Given this list of marker genes Fcf1, Abt1, Tbl3, Nop9, Rcl1, Utp23, here is a description of the gene set: Endonucleolytic cleavage within the 5'-External Transcribed Spacer (ETS) of a tricistronic rRNA transcript that contains the Small Subunit (SSU) rRNA, the 5.8S rRNA, and the Large Subunit (LSU) rRNA in that order from 5' to 3' along the primary transcript. Endonucleolytic cleavage within the 5'-ETS of the pre-RNA is conserved as one of the early steps of rRNA processing in all eukaryotes, but the specific position of cleavage is variable. Mouse Gene Set: GOBP_ENDONUCLEOLYTIC_CLEAVAGE_IN_5_ETS_OF_TRICISTRONIC_RRNA_TRANSCRIPT_SSU_RRNA_5_8S_RRNA_LSU_RRNA species: Mus musculus